Given this list of marker genes GDA, XDH, PRTFDC1, NT5C2, HPRT1, here is a description of the gene set: The chemical reactions and pathways resulting in the breakdown of GMP, guanosine monophosphate. studied in species Homo sapiens Human Gene Set: GOBP_GMP_CATABOLIC_PROCESS